The following is a description of a gene set: studied in species Mus musculus Mouse Gene Set: GOBP_NEGATIVE_REGULATION_OF_DOUBLE_STRAND_BREAK_REPAIR_VIA_NONHOMOLOGOUS_END_JOINING Any process that stops, prevents or reduces the frequency, rate or extent of double-strand break repair via nonhomologous end joining., and this is the list of marker genes: Cyren, Nudt16l1, Ercc6, Hsf1, Hmga2 (NCBI Gene Id 77357), Aunip, Mre11a